The following is a description of a gene set: Mouse Gene Set: GOBP_T_CELL_ACTIVATION species: Mus musculus The change in morphology and behavior of a mature or immature T cell resulting from exposure to a mitogen, cytokine, chemokine, cellular ligand, or an antigen for which it is specific., and this is the list of marker genes: Ada, Hmga1, Rps6, Ephb6, Gm13271, Prkcq, Trem2, Dnaja3, H2-Ea, Psen1 (NCBI Gene Id 19164), Nlrc3, Rhoa, Tespa1, Ihh, Tmem131l (NCBI Gene Id 229473), Ncaph2, Psg27, Runx2, Armc5, Il27, Apbb1ip, Chd7, Ifna15 (NCBI Gene Id 242517), Wnt4, Fanca, Smarcc2, Runx1, Clec4f, Lgals3, Nkap, Mill1, Gadd45g, Smad3, Hmgb1, Lepr, Lgals8, F2rl1, Gm13275, Bcl6, Ceacam15, Ctps1, Il2ra, Cd44, Cd209e, Gm13277, Itch, Ccl19-ps6, Ccl19-ps4, Prex1, Stat4, Il23a, Zmiz1, Gimap3, Slamf6, Ifng, Sema4a, Pla2g2f, Mir326, Il6ra, Clec4a4, Jmjd6, Fzd8, Foxp3, Traf2, Men1, Scgb1a1, Lgals9, Abl1, Ctsg, Ifnb1, Ceacam23, Zfp608, Zc3h12a, Il3, Foxo3, Ptpn2, Ins1, Bid, Zfp683, Nrarp, Csk, Zfp609, Il12a, Ccdc88b, Tsc1, Arid2, Duxbl1, Tnfsf11, Foxj1, Klhl25, Atp7a, Mdk, Cxcl12, Prkar1a, Cd80, Cd3g, Jaml, Prdx2, Slamf1, Stat6, H2-DMb2, Nfkbiz, Smarca2, Vsir, Rora, Il36b, Mr1, Ifna2, Fzd7, Fkbp1b, Slfn2, Brd2, Ccl5, Kit, Malt1, Hsph1, Itgax (NCBI Gene Id 16411), Cebpb, Spta1, Tyrobp, Sema6d, Alkbh5, Efnb3, Vnn1, Xbp1, Psmb10, Psen2, Pbrm1, Fyn, Dlg1, Ifna12, Nedd4, Pawr, H2-Oa, Cdkn2a, Clec4a3, Ctnnb1, Bcl11a, Arg1, Igf2, Ambra1, Smarcd1, Icos, Sit1, Kitl, Cd48, Cxcr4, Gja1, Cd3e, Tcf7, Slamf7, Ufl1, Tgfb1, Smad7, Bax, Ppp3ca, Btnl1 (butyrophilin-like 1), Il2, Cd4, Hotairm1, Cgas, Cblb, Dtx1 (NCBI Gene Id 14357), Ndfip1, Btnl2, Gpam, Cbfb, Dlg5, Ifnk, Ccl19-ps1, Ccl21d, Lilrb4a, Zfp36l1, Dapl1, Entpd7, Tnfrsf21, Irgm1, Pf4, Pla2g5, Icosl, Lfng, Ly9, Smarcd2, Foxp1, Zbtb32 (NCBI Gene Id 80652), Clec4d, Ifnab, Themis, Ccr9, Ceacam3, Cxadr, Lat, Fancd2, Cd274, Crip3, Txk, Rabl3, Il1b, Scart2, Slamf9, Gpr183, Eomes, Psg28, Sash3, Psg25, Abl2, Nkx2-3, Ido1, Gata3, Hsp90aa1, Cyp26b1, Ccl21e, Ceacam12, Spi1, Pdcd1, Tnfrsf14, Gimap5, Sox12, Drosha, Fosl2, Rab29, Socs6, Ptger4, Mad1l1, Sox4, Bcl3, Bcl11b, Cav1, Ctla2a, Zfp35, Smarcd3, Btla, P2rx7, Wdfy4 (WD repeat and FYVE domain containing 4), Clec4e (NCBI Gene Id 97322), Pik3r1, Cracr2a, Itgb6, Ripk3, Adam8, Dll4, Il7, Stk11, Phf10, Tbk1 (NCBI Gene Id 80470), Gpr18, Rps3, Sirpa, Cd24a, Ifna13, Card11, Vsig4, Clec4a2, Fas, Tnfaip8l2, Ager, Ccl20, Itk, Nck1, Psg21, Socs1, Rac2, Cd209d, Atf2, Wnt1, Psg23, Gli3, Itpkb, Blm, Ap3b1, Slfn1, Psmb11, Cd28, Il20rb, Hlx, Igtp, Hes1, H2-Ab1, Traf6, Klhl22, Ncor1, Ceacam1, Arid1a, Cacnb4, Xrcc4, Hs1bp3, Stat3, Nfatc3, H2-Eb2, Slc4a1, Tspan32 (tetraspanin 32), Ccnd3, Ikzf3, Mafb, Nhej1, Syk, Lck, Il1rl2, Tnfsf4, Zfp36l2, Azi2, Jag2, Rsad2, Hsh2d, Cd276, Tbx21, Cd209a, Ifna4, Pag1, Sdc4, Rag1, Kmt2a, Havcr2, Traj18, Cd74, Tnfrsf4, Zbtb7b, Glmn, Il4, Laptm5, Mtor, Pck1, Traf3ip2, Rasal3, Pnp, Casp3, Il18, Skint1, Trex1, Ifna11, Mpzl2 (NCBI Gene Id 14012), Shb, Tnfrsf1b, H2-DMa, Cd84 (NCBI Gene Id 320559), Ripk2, Cdh26, Sos1, Btn2a2, Sox13, Slc46a2, Rc3h1, Bmp4 (NCBI Gene Id 12159), Carmil2, Zp3, Pycard, Prelid1, Batf, Bcl2, Ifna5, Il15, Il6st (interleukin 6 signal transducer), Rhoh, Cd151 (CD151 antigen), Ins2, Ebi3, Clptm1, Adora2a, Tnfsf9, Shh, Myh9, Fadd, Ccl21b (NCBI Gene Id 20298), Erbb2, Rbx1, Cd59b, Il4i1, Clec4g, Wnt10b (wingless-type MMTV integration site family, member 10B), Fbxo38, Lgals1, Gm13283, B2m, Hspb1, Lcp1, Smarca4, Il12b, Cd47, Tmem98, Psg19 (pregnancy specific beta-1-glycoprotein 19), Sh3rf1, Lag3, Ccr7, Ikzf1, Psg17, Tnfrsf9, Tcf3, Kctd9, Ap3d1, Sp3 (NCBI Gene Id 320543), Il7r, Actb, Cd55b, Il12rb1, Stat5a, Ildr2, Il4ra, Slc4a2, Lrrc32, Abcc1, Ptpn22, Il2rg, Itgb8, Stoml2, Brd4, Jak2, Gba1, Pten, Tarm1, Rasgrp1, Bad, Cd8a, Vav1, Smarcc1, Tnfsf8, Ptpn6, Cd27, Vcam1, Hspd1, Cd70, Opa1, Dhps, Nlrp3, Grb2, Ifna14, Kat7, Ifna7 (interferon alpha 7), Cd6, Ccl21a, Pdcd1lg2, Kcnk18, Ifna16, Vtcn1, Elf4, Socs5, Adrm1, Rc3h2 (NCBI Gene Id 77277), Epo (erythropoietin), Igf1, Ccl19, Kat5, Ccl2, Prnp, Il18r1, Was, Ctla4, Ccr2, Actl6a, Zap70, Cyrib (CYFIP related Rac1 interactor B), Gimap1, Ceacam5, Ncstn, Muc19, Cd37, Mir873a, Efnb1 (NCBI Gene Id 13641), Mir301, Cd83, Fzd5, Ifnar2, Sart1, Tnfsf13b, Ctsl, Adam17, Ptprc, Ceacam13, Cd5, Cyld, Hfe, Trp53, Lax1, Psap, Cd81, Ifnar1, Usp44, Sos2, Anxa1, Zbtb1, Gpr89, Bcl10, Cd3d, Itgam, Clec2i, Itpripl1, Prdm1, Cd69, Rorc, Cd1d1, Dpp4, Myb, Ifna9, Coro1a, Pik3r6, Icam1, Dusp3, Treml2, Sla2, Brd7, Foxn1, Irf4, Stx11, Itgav, Cul4a, Arg2, Atg5, Irf1, Kdelr1, Itgal, Cd160, Tyk2, Tsc2, Gsn, Peli1, Egr1, Efnb2 (NCBI Gene Id 13642, ephrin B2), Tnfsf18, Gpnmb, Loxl3, Apc, Tox, Il1a, Gnrh1, Cd209c, Ccr6, Slc11a1, Smarce1, Cd8b1, Ifna6, Wwp1, Itgad, Slc7a1, Rara, Fgl1, Nckap1l (NCK associated protein 1 like), Tfrc (NCBI Gene Id 76361), Gm13276, Cd86, Cd300a, Fgl2, Ifne, Cd40lg, Dcaf12 (NCBI Gene Id 99997), Nfkbid, Kat2a, Pknox1, Fut7, Egr3, Smarcb1, Msn, Il6, Zc3h12d, Il21, Gm13272, Thy1, Dusp10, Patz1, Pax1, Ripor2, Prr7, Ddost, Relb, Rbx1-ps, Ceacam11, Marchf7, Cdk6, H2-T23, Spn, Fcho1, Flt3, Ephb4, Btnl6, Zeb1, Lig4, Flot2, Cd46, Nkg7, Tcirg1, Cd59a, Ptcra, Nr5a2, Enpp1, Selenok, Nck2, Dusp22, Rpl22, Lmbr1l, H2-DMb1, Bcl2a1d, Dock2, Lmo1, Cd1d2, Psg16, Ywhag, H2-M3, Lep, Rag2, Ceacam14, Crtam, Tigit, Twsg1, H2-Ob, Runx3, H2-Aa, Tnfsf14, Cd55, Chrna7, Ifna1, Fkbp1a, Ppp3cb, Ccl19-ps5, Scrib, Ankle1, Plxna1, Myc, Rab27a, Cd244a, Actl6b, Lipa, Ccl19-ps3, Otud5, Ccl21f, Xcl1, Mettl3, Eif2ak4, Tnfrsf13c, Lef1, Mink1, Lilrb4b, Dicer1, Pla2g2d (phospholipase A2, group IID), Jak3, Zc3h8, Washc1, Braf, Itgb2, Adk, Satb1, Dock8, Sh2b3, Ep300, Mapk8ip1, Tgfbr2, Igfbp2, Aire, Sftpd, Ascl2, Bmi1, Ifnz, Fcer1g, Pde5a, Pla2g2a, Srf, Prkaa1, Bag6, Znhit1, Prkdc, Sh2d2a, Psg26, Aif1, Stat5b, H2-Eb1, Prkcz